The following is a description of a gene set: from publication Cui A, Huang T, Li S, Ma A, Pérez JL, Sander C, Keskin DB, Wu CJ, Fraenkel E, Hacohen N (PMID 38057668) Cytokines mediate cell-cell communication in the immune system and represent important therapeutic targets. A myriad of studies have highlighted their central role in immune function, yet we lack a global view of the cellular responses of each immune cell type to each cytokine. To address this gap, the authors created the Immune Dictionary, a compendium of single-cell transcriptomic profiles of more than 17 immune cell types in response to each of 86 cytokines (>1,400 cytokine-cell type combinations) in mouse lymph nodes in vivo. A cytokine-centric view of the dictionary revealed that most cytokines induce highly cell-type-specific responses. For example, the inflammatory cytokine interleukin-1β induces distinct gene programmes in almost every cell type. A cell-type-centric view of the dictionary identified more than 66 cytokine-driven cellular polarization states across immune cell types, including previously uncharacterized states such as an interleukin-18-induced polyfunctional natural killer cell state. species: Mus musculus Mouse Gene Set: CUI_T_CELL_CD4_IL33_RESPONSE_UP Genes positively differentially expressed in cell type: CD4+ T cell upon treatment with cytokine: IL-33 in mouse lymph nodes in vivo., and this is the list of marker genes: Socs3, Igfbp4, Zbp1, Ly6a, Ifi27l2a